Given this list of marker genes Cep152, Deup1, Nfib, Plk4, E2f4, Foxj1, Ccdc78, Trp73, Ttc8, Mcidas, Gmnc, Ccno, Cep63, here is a description of the gene set: The process in which a relatively unspecialized cell acquires the specialized features of a multi-ciliated epithelial cell. Mouse Gene Set: GOBP_MULTI_CILIATED_EPITHELIAL_CELL_DIFFERENTIATION studied in species Mus musculus